Given this list of marker genes ZNF563, ARMT1, SUSD1, NEMP1, E2F6, RFX3, RAPGEF4, SMG1, AMPD1 (NCBI Gene Id 270), HS1BP3, H2BC13, CNKSR3, HLA-DOA, ABRAXAS1, S100PBP, TRIM21, C1orf21, GPR18, AHCYL1, MFAP3, IFT80, LRRC40, SUPT7L, AEN, STRADB, TRIM34, RASSF5, SESN3, LRTM2, BCS1L, ARGLU1 (arginine and glutamate rich 1), DNMT3A, HOOK3, ZNF841, ACVR1B, ZKSCAN8, AKAP5, EPHX1, CNOT3, NUFIP2, STAT1, UROS, TSSC4, ITGB3BP, TREML2, AASDH, GIMAP8, BRMS1L, CFAP65, MCOLN3, NAPG, SATB1, CEPT1, HMGA1, PCGF3, ZNF43, GABRR2, DENND2D, PWP1, SNORD89, PARP11, ZNF229, PRR14L, BTF3L4, PPM1B, SNN, RBM26, SESN1, GAA, HES6, DENND11, PRKCB, ALG8, CEP43, MTX3, ZNF354C, ZER1, PXMP4, TGFBR3, DLG1, HTT, PALS1, C2orf68, PGPEP1L, CENPJ, ITM2A, ERCC4, ZFC3H1, PPP1R35, ZNF266, TTC28, PDK1, FAM120A, DNTT, IGIP, GDI1, ERGIC2, SH3PXD2A, IRGM, ERBIN, ZNF408, TMIE, KCTD13, MAMDC4, POU3F2, DENND2C, ZNF592, CEP41, CC2D1B (NCBI Gene Id 84499), LIPT1, MTURN, TFAP4, BPHL, EMC8, IGF2BP2, MAP3K7, REV3L, SPX, USP18, STAG1, RNF170 (ring finger protein 170), RNF149, TERF2, SPSB1, PSMG1, IBTK (NCBI Gene Id 25998), ADAR (NCBI Gene Id 3427), RREB1, CERS6, SFXN2, STARD5, MSRB2, DGLUCY, FAM234B, NUP50, MGAT4A, ZNF329, TMEM42, GGA2, GPRASP2 (NCBI Gene Id 114928), TMEM41A, FBXL5, N4BP2, LRP5, MTAP, SLC30A7, BCL9, GUCA1B, PARD6G, ATP13A3 (ATPase 13A3), SGK3, SLC25A51 (NCBI Gene Id 92014), PTCH1, BCOR, ISOC1, EMC1, MSS51, LIMD2, CAPN3, AMER1, PIKFYVE, SLC26A6, HDAC7, MAP4K2, DCP2, GPR146, MRPS33, ABHD18, ARRB1, EXD2, COLGALT2, FTO, SOCS4, GOLGA1, MGST2, SDHAF1, PSMB2, SNRPG, CASD1, SAMD10, NR2C1, THAP2, PREPL, XKRX, RDH10, IREB2, ATP11B, MAST4, METTL18, ZNF445, TUBGCP4, INPP5B, NCDN, SIKE1, ELOVL7, SDAD1, ZBTB18, TRUB1, RERE, FNTB, here is a description of the gene set: from publication Feuerer M, Herrero L, Cipolletta D, Naaz A, Wong J, Nayer A, Lee J, Goldfine AB, Benoist C, Shoelson S, Mathis D (PMID 19633656) Genes up-regulated in comparison of lymph node conventional T cells versus fat tissue conventional T cells. studied in species Homo sapiens Human Gene Set: GSE7852_LN_VS_FAT_TCONV_UP Comparisons of global gene-expression profiles revealed a greater distinction between CD4+ Treg cells and CD4+ conventional (Tconv) T cells residing in abdominal (epidydimal) fat versus in more standard locations such as the spleen, thymus and LN.